The following is a description of a gene set: Genes up-regulated in activated CD4 T cells with MIR17 perturbation: knockout versus over-expression. miR-17 from the miR-17-92 cluster regulate activation-induced cell death in T cells and modulate inducible regulatory T cell differentiation. We used microarrays to detail the global program of gene expression modulated by miR-17 and aim to identify the potential targets of miR-17. Human Gene Set: GSE32533_MIR17_KO_VS_MIR17_OVEREXPRESS_ACT_CD4_TCELL_UP from publication Jiang S, Li C, Olive V, Lykken E, Feng F, Sevilla J, Wan Y, He L, Li QJ (PMID 21972292) studied in species Homo sapiens, and this is the list of marker genes: SPI1 (Spi-1 proto-oncogene), UNC13D, SKAP2, CTSC (NCBI Gene Id 50958), GSAP, IRAK3, USP8, UBASH3B, CD8A, TTC22, IKZF1, MED11, CCDC88B, USF1, CASTOR1, ACAD10, STAP1, SLC7A8, NCF2, GALNT7, KRT16, AHCYL2, WDR1, C16orf54, TUBB6 (tubulin beta 6 class V), PDZD8, MCM10, GAPVD1, UBTD1, CCDC87, OSTF1, SGPL1, INPP5D, TMEM169, PPHLN1, PPP1R14B, CD86, RIPK3, LIPH, ZC3H13, SRGN, FEZ2, GPR18, FIBCD1, OPN1LW, CYTH4, SLA, PIK3AP1, EVI2B, PRDM9, AKR1B1, GALK1, SHPK, NCF1, TFE3, FYB1, PTPN6, OLFM2, SPCS2, AFTPH, DENND1C, CDCA5, RASSF2, CCL5, MYO5A, ITSN2, AGFG1, FCGR2B, RNF149, GPRC5D, TSSK3, C16orf96, N4BP2L2, KCNK13, DDX39A, PHF21B, PTPRC, DENND1A, PTPRJ, PDZK1IP1, PISD, TTC7A, HPX, ATP8B4, PLA2G15, GNPTAB, RAB3IL1, GATM, LYZL4, PPM1H (NCBI Gene Id 57460), CFAP157, SIRT7, DIRAS1, DIAPH1, SEZ6L2, NLRC5, ZRANB3, GPR35, CD72, C2orf80, FMNL2, CD8B, PFN1, LYN, PIGA, EOMES, GZMK, POU2F2, CYFIP2, HNRNPM, CEBPG, ARPC5, YIF1B, CATSPERZ, DHRSX, C19orf38 (NCBI Gene Id 255809), CA12, OCEL1, VAMP3, PCTP, ACP5, SIPA1, CSF3R, COTL1, RBM41, RENBP, HBE1, LDLRAP1, SIGLEC7, APOBEC1, ARL4C, TRIM8, TNFRSF1B, PKIB, MFSD11, HK3, RAB5C, LHX5, NUP160, TPD52, TNFRSF11A, IMPDH1, PAIP1, EPOP, ATXN7L1 (NCBI Gene Id 57485), SLC14A1, CSK, CDC42SE2, RTN3, CTSB, CHCT1, SAMD7, SHTN1, SPAST, UPP1, XYLT2, YWHAH, TM6SF1, SLC8B1, RASAL3, PTPN22, PPP4R4, PSMG4, IL31, EMC1, KNOP1, PTPRE, COL20A1, BASP1, SNRNP35, EDEM1, BMP2K, IRF8, GFI1 (growth factor independent 1 transcriptional repressor), C4orf19, DOCK11, FES, MAFB, KHDRBS1, TMEM26, TBC1D9, PGLYRP2, IL36RN, HFE, PTBP1, C3AR1, CXCL10, SLC28A2, SAMD1, IPCEF1, METAP2, SFT2D1, CHRNB2, SPN, FAM222A, INTS5, TIFAB, TRAIP, SMIM14, TMEM243